Given this list of marker genes CDC45, SKP2, SEM1, ORC1, FEN1, PSMB6, RFC3, UBC, DNA2 (DNA replication helicase/nuclease 2), RFC1, PSMC4, PSMA7, PSMC3, GINS2, ORC6 (origin recognition complex subunit 6), PSMC1, ANAPC16, MCM4, PSMA4, CCNA1, CUL1, POLD2, PSMD6, ORC5, CDK2, PSMD1, UBB, RPA3, PSMB3, RPA2, PSMD3, MCM5, RBX1, PSMD11, CCNA2, MCM3, PSMA3, RFC2, PSMA5, ADRM1, CDC6, LIG1, ANAPC11, PSMC5, ANAPC2 (anaphase promoting complex subunit 2), ANAPC15, CCNE2, PSMB7, POLE2, ORC3, PSMD14, POLE3, PRIM2, GINS3 (NCBI Gene Id 92916), GINS1 (GINS complex subunit 1), POLD1, MCM2, POLA1, UBE2D1, PSMB4, PSMD8, PSMB2, PSMD13, UBE2E1, ANAPC7, PSMA1, FZR1, UBA52, UBE2C, ANAPC1, PSMA6, MCM6, PSMD2, POLE4, ANAPC4, CDT1, ANAPC5, PSMB1, UBE2S, PSMD12 (NCBI Gene Id 5718), PSMC6, ORC2, CDC23, RPS27A, GINS4, CCNE1, SKP1, RFC5, ORC4, RFC4, CDC27, POLD4, PSMC2, CDC26, PSMB5, PSMA2, GMNN, PRIM1, CDC16, POLD3, MCM7, PSMD7, POLA2, MCM8, ANAPC10, RPA1, PCNA, POLE, here is a description of the gene set: Human Gene Set: REACTOME_SYNTHESIS_OF_DNA Synthesis of DNA studied in species Homo sapiens